The following is a description of a gene set: from publication Gaussmann A, Wenger T, Eberle I, Bursen A, Bracharz S, Herr I, Dingermann T, Marschalek R (PMID 17130830) The reciprocal chromosomal translocation t(4;11) is correlated with infant, childhood, adult and therapy-related high-risk acute leukemia. Here, we investigated the biological effects of MLL.AF4, AF4.MLL or the combination of both reciprocal fusion proteins in a conditional in vitro cell culture model system. Several parameters like cell growth, cell cycling capacity, apoptotic behavior and growth transformation were investigated under physiological and stress conditions. Co-transfected cells displayed the highest resistance against apoptotic triggers, cell cycling capacity and loss-of-contact inhibition. These analyses were complemented by gene expression profiling experiments and specific gene signatures were established for each of the three cell lines. Interestingly, co-transfected cells strongly upregulate the homeobox gene Nanog. In combination with Oct4, the Nanog homeoprotein is steering maintenance of pluripotency and self-renewal in embryonic stem cells. Transcription of Nanog and other stem cell factors, like Oct4 and Bmi1, was verified in biopsy material of t(4;11) patient cells which express both reciprocal t(4;11) fusion genes. In conclusion, the presence of both reciprocal MLL fusion proteins confers biological properties known from t(4;11) leukemia, suggesting that each of the two fusion proteins contribute specific properties and, in combination, also synergistic effects to the leukemic phenotype. Down-regulated genes from the set G (Fig. 5a): specific to cells expressing both MLL-AF4 and AF4-MLL fusion proteins. Human Gene Set: GAUSSMANN_MLL_AF4_FUSION_TARGETS_G_DN studied in species Mus musculus, and this is the list of marker genes: CST6, RPS6KA2, ING5, LRCH2, RAB39B, CCDC91, ZCCHC2, ETV1, ARL14EP, AHNAK, RNF128, ELMO1, DGCR6, CPEB1, GCH1, FAM171B, GPR19, WNT4, NSD2, WDR62, DUS4L, AKR1B1 (aldo-keto reductase family 1 member B), MEGF10, DYRK3, CHST1, TMEM243, SLC6A8, SERPINB8, NMT2, MTM1, ESS2, VCAN, PCK2, CPOX (coproporphyrinogen oxidase)